The following is a description of a gene set: A dendrite that emerges near the basal pole of a neuron. In bipolar neurons, basal dendrites are either on the same side of the soma as the axon, or project toward the axon. Human Gene Set: GOCC_BASAL_DENDRITE studied in species Homo sapiens, and this is the list of marker genes: SLC17A8, MAP2, SLC4A10, YKT6, MAP1B, MAPK8